Given this list of marker genes Prc1, Anapc5, Cdca7, Cdca3, Kif23, Cdc20, Smarca4, Kif22, Hmgb1, E2f8, Top2a, Melk, Cbx1, Aurka, Cdca5, Anp32e (acidic nuclear phosphoprotein 32 family member E), Slbp, Smarcc1, Ramp1, Asf1b, Lgals1, Fancc, H2az1, H2ac6, Hmgb3, Tubb5, Txn1, Lmnb1, Enpep, Xrcc6, Hjurp, Rrm1 (NCBI Gene Id 20133), Igll1, Hmgn2, Cdkn1a, Rangap1, Ccnb1, Alyref, Ide, Cdkn2c, Slc12a3, Cenpl, Ccna2, Mcm2, Cmc2, Bub3, Ppp2r5c, Calm2, Tmpo, Cdk1, Ttk, Prdx4, Mki67, Kpna2, Hmga1, Ran, Tubb4b, Racgap1, Haus3, Rrm2, Lig1, Nucks1 (nuclear casein kinase and cyclin-dependent kinase substrate 1), Dtl, H2ax, Ccnb2, Cdkn3, H2az2, Psmc1, Mcm6, Zfp358, D17H6S56E-5, Hnrnpab, Cenpa, Rad21, Ncaph, Mcm7 (NCBI Gene Id 17220), Ube2s, Cks1b, Rbbp4, Tuba1a, Smc2, Lgals9, Smc4, Mcm3, Cenpe, Stmn1, Slc29a1, Mybl2, here is a description of the gene set: The Emu-myc transgenic mouse has provided a valuable model for the study of B-cell lymphoma. Making use of gene expression analysis and, in particular, expression signatures of cell signaling pathway activation, we now show that several forms of B lymphoma can be identified in the Emu-myc mice associated with time of tumor onset. Furthermore, one form of Emu-myc tumor with pre-B character is shown to resemble human Burkitt lymphoma, whereas others exhibit more differentiated B-cell characteristics and show similarity with human diffuse large B-cell lymphoma in the pattern of gene expression, as well as oncogenic pathway activation. Importantly, we show that signatures of oncogenic pathway activity provide further dissection of the spectrum of diffuse large B-cell lymphoma, identifying a subset of patients who have very poor prognosis and could benefit from more aggressive or novel therapeutic strategies. Taken together, these studies provide insight into the complexity of the oncogenic process and a novel strategy for dissecting the heterogeneity of B lymphoma. from publication Mori S, Rempel RE, Chang JT, Yao G, Lagoo AS, Potti A, Bild A, Nevins JR (PMID 18922927) studied in species Mus musculus Up-regulated genes in the B lymphocyte developmental signature, based on expression profiling of lymphomas from the Emu-myc transgenic mice: the Large Pre-BII stage. Mouse Gene Set: MORI_LARGE_PRE_BII_LYMPHOCYTE_UP